Given this list of marker genes MDH2, CSAD, IP6K2, ASS1, CACNA1H, FADS2, HSD17B4, LPCAT3, CYP39A1, P2RY6, PYCARD, SCP2, SRD5A2, LDHC, DBH, MIR98, KYNU, HACD3, CD74, BCAT2, ENSG00000274276, KPNB1, PTGDS, AMACR, NR3C1, PLTP, HSD17B3, AVPR1B, SLC39A14 (solute carrier family 39 member 14), SERINC5, IL1B, SLC27A5, GGT2P, PGAM1, SHMT1, ACADM, BCAT1, SCD, IPPK, APOC1, TECRL, FADS2B, XBP1, COQ7, FASN, MLXIPL, ELOVL7, SREBF1, CTH, KAT2B, ALOX12B (arachidonate 12-lipoxygenase, 12R type), HTD2, HSD17B10, PRKAG3, GBA1, PLOD2, MECR, NAGS, SCAP, PNPO, ABCD3, PLAA, CAD, EGR1, PTGES3, APOA4, THTPA, HMGCS1, SIRT2, RBP4, PGAM2, APOB, CYP11B2, SLC25A19, LIPA, ADIPOQ, GCG, CREB1, PGD, SDS (NCBI Gene Id 10993), SPTSSB, ASAH1, SPTLC1, ACADVL, NNMT, EBP, HSD17B7, SLC27A2, ABCA2, AQP8, UGP2, PNLIPRP2, APOC3, MAPDA, SIRT6, DEGS1, KLHL25, ALDH18A1, HAO1, ABCG4, ALOX15, GFI1, NSDHL, TMEM135, EP300, PYCR1, SIRT5, PPARGC1A, PCBD1, OSBP, CYP4A11, ABHD2, BMP6, TM7SF2, CYP2R1, FADS6, UGDH, CYP51A1, MTHFD1L, GPRC6A, CYP27A1, ABCG1, RBP1, CARNS1, MBTPS1, C7orf50, PGK2, TK2, PGM1, P2RY1 (purinergic receptor P2Y1), CFTR, ACER1, OTC, OSBPL9, AGXT2, SNAI1, STARD4, SPR, ERLIN1, HMGCLL1, GPR146, PLA2G4A, ALDOB, TPI1, MIR30C1, MSMO1, MPO, QNG1, WDR5, GLS2, SERINC3, ACOT8, NR1H4, CYP2C9, ACSL1, EHHADH, ACOT4 (NCBI Gene Id 122970), TBXAS1, DAGLB, INSIG2, PYCR3, OSBPL3, GGCX, SNCA, PLCG2, ACER3, PDXK, GOT1, SLC45A3, GLS, GGTLC3, ACSS3, AKR1C3, GOT1L1, G6PC1, ACSM1, GLUD1, PTGS2, ENO3, COQ3, APIP, BRCA1, DECR2, CYP11B1, IPMK, SIRT1, MID1IP1, PECR, GAD2, LHB, NDUFAB1, DHRS9, DHCR24, GGTLC2, IMPA1, PTH, RFK, CYP24A1, CPS1, ACSM2A, APOE, PTPN2, DHRSX, GSTP1, HSD17B12, SRR, RDH10, COQ4, PNLIP (NCBI Gene Id 5406), ALOX5, PTGES, ELOVL1, GSTM1 (NCBI Gene Id 92085), ACSM5 (acyl-CoA synthetase medium chain family member 5), WNT4, SLC1A3, LEPR, ADM, GAMT, CYP1A2, ITPKC, SORD, OXSM, FOXO1, PKLR, PROX1, GAD1, GGT1, ACSF3, GATM, MTHFD2, ACSBG2, DHFR2, OSBPL1A, ITPKB, MALRD1, SEC14L2, HMGCS2, PLEK, PRTFDC1, CHST15, ALDOC, PRG3, DNPH1, CLN3, OLAH, NAIP, LEP, EDN1, MIR103A1, PRKAG1, NTSR1, ACSM4, SPTLC3, NLRC4, CASP1, FBP2, OGT, TPK1, PIBF1, BAAT, PLA2G3, AKR1D1, CLK2, ATF4, PYCR2, PRKACA, ACOT7, ATF3, C1QTNF12, BMP5, KMO, HSD17B8, HMGCR, UROS, PLPP6, CYP7B1, OSBPL2, ALDH1A2, ELOVL3, UBIAD1, HAAO, SPHK2 (sphingosine kinase 2), COQ9, GGT3P, GOT2, KAT2A, GSTM2, MVK, AVPR1A (arginine vasopressin receptor 1A), SIK1, LTC4S, CBR1, ELOVL4, SLC37A4, FDPS, ADK, PLOD3, PLA2G10, REST, ACSBG1, ASNS, MIR766, IDI1, IDO1, PRKAA2, GLUD2, SLC19A2, PTGS1, BGLAP, ASL, MGLL, MIR96, AACS, MTHFD1, SLC19A3, PCBD2, THNSL2, RANBP2, LIAS, STARD3, ELOVL5, AKR1C4, ACLY, ARV1, LHCGR, ALOX12 (NCBI Gene Id 239), FMO3, PTS, GSTM4, ARPP19, MIR33A, ADI1, LIPC, NLN, GLUL, MIR342, FADS3, OAT, SUCLA2, CYB5R3, APOA1, PNPLA8, INS, IFNG, APOA5, AKR1B1, KDM3A, G6PD, PPIP5K1, NOXRED1, FABP5, FGFR4, ALOX15B, ACMSD, ACSM6, ERLIN2, PLP1, MTRR, TNF, ACSM3, COQ2, GIP, MIR182, CEACAM1, PLA2G1B, NDUFA9, PDK4, UCKL1, FA2H, ACACA, IP6K1, MIR185, CDO1, MLYCD, CLCN2, INSIG1, AGK (NCBI Gene Id 55750), PC, PNLIPRP1, NANP, ENO2, G6PC3, SREBF2, DKK3, DHFRP1, CYP3A4, LTA4H, SPTLC2, DTYMK, MTR, PARK7, APOC2, PRKAA1, PRXL2B, LPGAT1, PSPH, SYK, BHMT2, CYP4F11, IDI2, HACD4, GPD1, CYP8B1, NR1H3, LPL, PRMT3, ACAA2, IP6K3, DPYD, PPP4R3A, FDX2, SPHK1, PGK1 (phosphoglycerate kinase 1), NUS1, MGST3, TRIB3, DKKL1, ACOX1, CRTC2, MOXD1, SIRT7, LSS, PNLIPRP3, INHBA, ALDH8A1, PRKAB2, SPTSSA, FDXR, MIF, QDPR, MTAP, GATD1, ELOVL2, PGP, ENOPH1, PER2, CYP2D6, PNP, FDFT1, ABAT, FBP1, NPC1L1, PMVK, ACACB, MIR107, FGF1, ENO1, PTGIS, CYP2E1 (NCBI Gene Id 1571), GGT7, PPP4R3B, IMPA2, FADS1, GPD2, MVD, DHDDS, SDHAF3, HMGCL, SLC25A13, PDSS1, MIR548P, ACSM2B, PAH, CES1, CBR4, FMO1, BHMT, CBS, STARD7, PDK2, MCAT, PTGES2, NFKB1, FGF19 (fibroblast growth factor 19), CYP27B1, UPB1, STAR, LGSN, PCK2, BMP2, WDTC1 (NCBI Gene Id 23038), CYP1A1, GPI, GPER1, EDN2 (NCBI Gene Id 1907), ABHD3, ADCK2, PPTC7, ERFE, ABHD1 (NCBI Gene Id 84696), AVP, C1QTNF3, ZNF692, SCD5, PLA2G5, PRPS1, ALDH1A1, GGT5, ERRFI1, TECR, RTN4IP1, ALOXE3, MAPK1, SESN2, EIF6, CYP7A1, CYP4A22 (cytochrome P450 family 4 subfamily A member 22), ACADL, MIR132, PRKAG2, ACSL4, PFKFB1, ASNSD1, HSD17B1, SEPHS2, HACD2, PSAT1, DCAF5, MOXD2P, PLA2G4F, PPIP5K2, COQ5, CD244, ALOX5AP, NR1D1, DGKQ, GNAI1, H6PD, ISYNA1, PPARA, HACD1, COQ6, GCH1, PAQR3, FSHB, SC5D, SHMT2, ADA2, MTCL2, DGAT2, PHGDH, CYP2C8, GPIHBP1, GCK, PGM2, ASAH2, UBR4, GGT6, CRY1, TCF7L2, ABCD1, SLC25A11, PCK1, SELENOS, MGST2, MST1, ACER2, HOGA1, ATP2B4, MBTPS2, AGXT, LBR, SLC35B4, ADA, PDSS2, SNAI2, APRT, OSBPL7, DAB2, HSD3B7, NT5E, PTAFR, DHFR, SRD5A3, DHCR7, SERPINA12, QKI, TK1, SLC38A1, ACSS1, ALDH1A3, ANGPTL4, SEPHS1, GNMT, PTH1R, ACSS2, OSBPL6, DDB1, ELOVL6, DCTD, PRKG1, ACOX2, MIR204, ABCB11, COQ8A, USP7, COQ8B, CYP46A1, ITPKA, SLC25A10, GNE, CYP19A1, ADCYAP1R1, GPX4, GGTLC1, NANS, HPRT1, HPGDS, LIPG, CTHRC1, GGTA1, PRKAB1, ABCD2, G6PC2 (NCBI Gene Id 57818), NR0B1, BCO1, NR1H2, here is a description of the gene set: species: Homo sapiens The chemical reactions and pathways resulting in the formation of small molecules, any low molecular weight, monomeric, non-encoded molecule. Human Gene Set: GOBP_SMALL_MOLECULE_BIOSYNTHETIC_PROCESS